The following is a description of a gene set: Genes representing Th1 / cytotoxic module in sputum during asthma exacerbations. Asthma exacerbations are associated with subsequent deficits in lung function. Here, we tested the hypothesis that a specific pattern of inflammatory responses during acute exacerbations may be associated with chronic airway obstruction. Gene coexpression networks were characterized in induced sputum obtained during an acute exacerbation, from asthmatic children with or without chronic airflow limitation. The data showed that activation of Th1-like/cytotoxic and interferon signaling pathways during acute exacerbations was decreased in asthmatic children with deficits in baseline lung function. These associations were independent of the identification of picornaviruses in nasal secretions or the use of medications at the time of the exacerbation. Th2-related pathways were also detected in the responses, but variations in these pathways were not related to chronic airways obstruction. Our findings show that decreased activation of Th1-like/cytotoxic and interferon pathways is a hallmark of acute exacerbation responses in asthmatic children with evidence of chronic airways obstruction. from publication Bosco A, Ehteshami S, Stern DA, Martinez FD (PMID 20336062) Human Gene Set: BOSCO_TH1_CYTOTOXIC_MODULE studied in species Homo sapiens, and this is the list of marker genes: F13A1, SSTR2, IL12RB2 (interleukin 12 receptor subunit beta 2), RRM2, RUNX3, CALHM6, OR6K6, CXCL11 (C-X-C motif chemokine ligand 11), IL4I1, APOL3, FUT2, FBXO39, TSHZ3, ISG15, GIMAP8, IL15RA, TNFSF18, HAMP, SH2D1A, MYBL1, CRABP1, ENPP2, KLRD1, IL21, GNLY, F2R, ADAM3A, RHBDF2, CCR5, BCL2L14, P2RX5, IRF4, ANKRD22, NKG7, ANXA2R, CMPK2, STAB1, GIMAP5, GAS6, DNA2, RGL1, SMOX, IL2RA, GZMK, KLHDC1, STAT4, ADAM19, MKI67, CXCL10, TMEM229B, CD5, CH25H, KNL1, SOCS1, TYMS, PRF1, SLA2, HAPLN3 (hyaluronan and proteoglycan link protein 3), OR5D14, CDK6, CCL8, SLAMF1, RNASE2, TRAT1, RTP4, BATF2, DPCD, SAMD3 (sterile alpha motif domain containing 3), GZMB, IFNG, GIMAP4, CERS4, HERC6, SDS, ARNT2, IDO1, OR2A5, FFAR3, MERTK, ABCB1, ITGA9, MS4A6E, CEMIP, CXCL9, ADORA3, CD28, CDC7 (NCBI Gene Id 8317), CTLA4, CD38, IL10, PRKCQ, STRIP2, GPR171, CD163L1, BCL2, ATF5, USP18, HS3ST3B1, IL15, CMKLR1, GIMAP7, PRKCA (NCBI Gene Id 5578), PLEKHO1, IFNB1, GBP6, CD300E, PTGER2 (NCBI Gene Id 63381), CCL7, LILRB5, FAM20A, FCGR2B, ACOD1, HESX1, TXK